Given this list of marker genes Hps1, Fkrp, Ccdc88c, Dcaf11, Mecp2, Spef2, Adora1, Pbx3, Stk40, Bloc1s6, Stard7, Tshz3, Ecel1, Atp1a2, Ccbe1, Tcf15, Mtg1, Hmga1, Ndufs4, Adh5, Ywhaz, Ap3b1 (adaptor-related protein complex 3, beta 1 subunit), Tnnc1, Adrb2, Selenon, Spag16, Odad4, Nlgn2, Mtg2, Col6a1, Nlgn1, Vangl1, Spag6l, Gsx2, Gls, Nek10, Rab3a, Gaa, Ttll1, Cc2d1a, Ddit3, Cfap221, Hoxa5, Zfand5, Jag2, Glra1, Nlgn3, Kdm6a, Phox2b, Hipk2, Ndn, Tlx3, Cfap54, Cfap43, Flt4, Dnah9, Fto, Drc1, here is a description of the gene set: Mouse Gene Set: GOBP_RESPIRATORY_SYSTEM_PROCESS studied in species Mus musculus A process carried out by the organs or tissues of the respiratory system. The respiratory system is an organ system responsible for respiratory gaseous exchange.